Given this list of marker genes MPO, ZSCAN30, RAP2C, OSBPL11, GCNT4, YWHAG, YEATS2, UHMK1 (U2AF homology motif kinase 1), CLCN3, CSDE1, PRPS2, RALB, BMPER, ARPP21, EXOC6, CFD, RIMS4, RAP2A, PNPLA1, TGFB1, DCAF10, PXT1, GAREM1, PPP6C, NUDT16, RAP2B, UBE2Q2, EHD2, RSL1D1, DNAH5, WNT9B, MRE11, ARID5B, RO60, DDX54, CIMAP1C, MOSMO, POMGNT2, LDHAL6B, DNAJB6 (NCBI Gene Id 9186), TEC, LRRC28, GPR63, VPS36, KLHL32, PPP1R1C, MACIR, CNR1, SUCO, DCAF5, ZNF189, ARAF, CBR1, GTF3C2, LRRC19, IGSF1, TBC1D19, RBM18, CNRIP1, SYNGR1, SRSF10, TAX1BP1, SGCB, SCLT1, PPP3R2, UQCC2, NDUFAF4, DMXL1, RHOQ, SYDE1, PHF13, SV2B, TK2, here is a description of the gene set: Human Gene Set: MIR7158_5P Genes predicted to be targets of miRBase v22 microRNA hsa-miR-7158-5p in miRDB v6.0 with MirTarget v4 prediction scores > 80 (high confidence targets). from publication Chen Y, Wang X (PMID 31504780) studied in species Homo sapiens